The following is a description of a gene set: Mouse Gene Set: GOMF_CELL_MATRIX_ADHESION_MEDIATOR_ACTIVITY The binding by a cell-adhesion protein on the cell surface to an extracellular matrix component, to mediate adhesion of the cell to the extracellular matrix. studied in species Mus musculus, and this is the list of marker genes: Madcam1 (mucosal vascular addressin cell adhesion molecule 1), Itga9, Itga10, Itga11, Svep1, Itga2, Emilin1, Itga1, Itgb1